The following is a description of a gene set: Chordee Human Gene Set: HP_CHORDEE studied in species Homo sapiens Ventral (i.e., downward), lateral, or ventrolateral curvature of the shaft and glans penis of more than 30 degrees., and this is the list of marker genes: KDM1A, PTDSS1, CARS1, HOXA13, PSMD12, SRY, COX7B, ZNF699, NDUFB11, MAP3K1, ZMYM2, PPP1R12A, EIF4A2, HCCS, ZEB2, POR, FGFR1, CDC42BPB, RERE, BBS2, MYH3, DYRK1A